Given this list of marker genes Grik1 (glutamate receptor, ionotropic, kainate 1), Slc6a1, Cnr2, Stxbp1, Htr1b, Adora1 (NCBI Gene Id 98749), Npy5r, Drd4, Bdnf, Cntnap2, here is a description of the gene set: species: Mus musculus Any process that stops, prevents, or reduces the frequency, rate or extent of GABAergic synaptic transmission, the process of communication from a neuron to another neuron across a synapse using the neurotransmitter gamma-aminobutyric acid (GABA). Mouse Gene Set: GOBP_NEGATIVE_REGULATION_OF_SYNAPTIC_TRANSMISSION_GABAERGIC